The following is a description of a gene set: studied in species Mus musculus Genes predicted to be targets of miRBase v22 microRNA mmu_miR_6913_5p in miRDB v6.0 with MirTarget v4 prediction scores > 80 (high confidence targets). Mouse Gene Set: MIR_6913_5P from publication Chen Y, Wang X (PMID 31504780), and this is the list of marker genes: Pstpip1, Cramp1, Dmbx1, Entpd6, Srp54b, Fam222b, Mocs1, Shisa7, Prdm2, Taok2, Foxj3, Col26a1, Gsk3b, Hnrnpa3, Ndst1, Agxt2, Nfasc, Rgs3, Pip4k2c, Glis3, Notum, Nampt, Dclk2, Col9a2, Ilk, Mtcl1, Prelp, Appl1, Lhx4, Myo5c, Stra6, Rgsl1, Nsfl1c, Sp1, Chek1, Dennd4a, Cox16, Lpcat3, Stra6l, Bbln, Srp54c, Rnase1, Ncoa2, Setbp1, Arl8a, Dnajb1, Sult1b1, Pacs1, Sesn2, Calcr, Evi2b, Tmtc1, Syt6, Fto, Clvs1, Srebf2, Golga7, Krt75, Sectm1b, Vav2, Slc8a1, Znrf3, Tppp, Prokr1, Cenpf, Mri1, Cdk6, Kcnj6, Fnip2, Zbtb39, Sgsm1, Maf1 (NCBI Gene Id 68877), Polr3b, Tspan18, Tspan5, Vwa5a, Lrfn2, Smg5, Homer1, Cyb561d2, Ifi44, Snai1, Ankfy1, Mcm3, Sestd1, Cdc42se1, Ezh1, Aqp4, Atf7, Tex13b, Bahcc1, Klhl34, Celsr3, Ciao2a, Gria3, Hs1bp3, Lfng, Zdhhc2, Caly, Kirrel1, Atp6v0c, Ccdc78, Grid2ip, C2cd4c, Lsm11, Gucy1a1, Egr3, Hmmr, Ptpn9, Entrep2, Lifr, Gm4787, S2bpcox16, Bcorl1, Setd5, Pnkd, Ino80c (NCBI Gene Id 225280), Hipk1, Hcrtr2, Ankrd63, Tcf25, Retreg3, Nfatc4, Zdhhc8, Slc4a10, 6430550D23Rik, Gabbr1 (gamma-aminobutyric acid type B receptor subunit 1), Rad51ap1, Ndrg1, 6030458C11Rik